The following is a description of a gene set: Mouse Gene Set: GOBP_POSITIVE_REGULATION_BY_SYMBIONT_OF_ENTRY_INTO_HOST species: Mus musculus Any process that activates or increases the frequency, rate or extent to which it enters into the host organism, where the two organisms are in a symbiotic interaction., and this is the list of marker genes: Bsg, Trim11, Tmprss2, P4hb, Trim30a, Cd4, Hmgb1, Cd74, Smpd1 (sphingomyelin phosphodiesterase 1, acid lysosomal), Lgals1, Tmprss4, Trim38, Furin